The following is a description of a gene set: Fucose-containing glycans play important roles in immunity and signalling. Fucosylated glycans are created by fucosyltransferases, which require the high-energy donor substrate GDP-fucose. Two pathways for the synthesis of GDP-fucose exist in mammalian cells; the GDP-mannose-dependent de novo pathway provides the majority of GDP-fucose whereas a minor contribution comes from the free fucose-dependent salvage pathway (Becker & Lowe 2003). part of: Synthesis of substrates in N-glycan biosythesis Reactome Pathway: GDP-fucose biosynthesis species: Homo sapiens, and this is the list of marker genes: FPGT, GFUS, FUOM, GMDS, SLC35C1, FCSK